Given this list of marker genes CNP, IFIT3, IFIH1, SMARCD1, PPP1R12C, PRICKLE2, TRIM14, RSRP1, MAP3K12, ATOX1, TAPBP, AKR1A1, PTRHD1, PARP9, MPPE1, JAK2, ATG16L1, C19orf12, MYH9, ARHGEF16, UPK3BL1, ZUP1, CAMKK2, EDF1, RPL31, NAA25, FZD5, SEMA4F, RPL24, BLVRB, MYH6, WDR33, STARD3, DENND1A, RELB, SETDB2, LRRK1, PA2G4, GDI1, RIGI, C1orf53, BORCS8, ATP8B3 (NCBI Gene Id 57203), RPL27, SOS1, MICAL1, STX8, PSME2, OAS1, PDCD1, CHKB, POLR2J, SHISA5, IKZF1, MARK2 (microtubule affinity regulating kinase 2), PODXL2, RNF213, MED15, PTTG1, TREML2, SHROOM1, NPEPPS, ACADL, HERC6, OAS3, NDUFAF3, MINAR1, MARF1, PDE1A, NTSR1, PCNX2, EAF2, ST3GAL1, CYP26A1, S100A13, TMEM184B, PIK3AP1, SLC15A1, FAM229A, COL13A1, SGCE, ORAI1, IRF5, KANSL3, TRIB1, KCNC3, UBR4, RDH5, HSF4, ANKRD12, PRSS41, PMP22, SLC22A8, ARHGEF2, AP3M2, CDC34, SLC25A40, TOR1AIP1, CYP27A1, PML, GTPBP1, MYO1G, KLHL36, SLC4A2, PSENEN, NDUFA11, FRMD4A, EPHX2, XAF1 (NCBI Gene Id 54739), MELTF, SMOX, HTT, HASPIN, TUBB2B, IRF9, NLRX1, VNN1, LGMN, HR, LIMD1, FLJ13224, CABP2, SLC30A1, HMOX2, UQCC2 (NCBI Gene Id 84300), TPPP3, PRKCE, NUDT14, TYROBP, RPS14, SERPING1, TRAFD1, ERLIN1, MX2, SNX6, RNF114, HLA-E, SCAMP2, DENND1C, ZCCHC2, CACNA1A, CXCR4, CDCA5, SERTAD1, ALKBH6, KLK6, ACKR2, SLC30A3, TMEM140, DZIP3, STPG4, MTHFSD, CDH15, DYNC1H1, LONP2, CMPK2, IP6K1, CASP3, RPL41, ATXN7L3B, ATXN7L2, PTRH2, DOCK6, DCK, ARID3B, PACSIN1, SGCB, WIPF2, BRI3, PRSS58, SART3, IRF7, PISD, PPP1R13B, CHCHD7, SELENOM (selenoprotein M), ATP5F1E (NCBI Gene Id 514), RBM43, SLAMF9, PIK3R5, DHX58 (DExH-box helicase 58), CIAO2B, LAPTM4B, RPL22 (NCBI Gene Id 65281), EXOC3L4, TYK2, VPS28, SAMD9L (sterile alpha motif domain containing 9 like), CA11 (NCBI Gene Id 770), SLC25A22, CECR2, ARHGAP30, KEAP1, BLOC1S1, ZNF703, PAM16, ZSWIM3, ADCK1, SNN, S100A6, here is a description of the gene set: Genes up-regulated in follicular B cells versus day 7 memory B cells. To obtain insight into the genetic basis of the increase of functional activity of memory B cells over time, we compared the gene expression profiles of day 7 and day 40 NP-specific/IgG1 memory B cells, GC B cells and plasma cells in immunized WT mice and naïve B cells, before and after activation in vitro. Human Gene Set: GSE11961_FOLLICULAR_BCELL_VS_MEMORY_BCELL_DAY7_UP from publication Kaji T, Ishige A, Hikida M, Taka J, Hijikata A, Kubo M, Nagashima T, Takahashi Y, Kurosaki T, Okada M, Ohara O, Rajewsky K, Takemori T (PMID 23027924) species: Homo sapiens